The following is a description of a gene set: Reactome Pathway: PECAM1 interactions This event has been computationally inferred from an event that has been demonstrated in another species.<p>The inference is based on the homology mapping from PANTHER. Briefly, reactions for which all involved PhysicalEntities (in input, output and catalyst) have a mapped orthologue/paralogue (for complexes at least 75% of components must have a mapping) are inferred to the other species. species: Mus musculus part of: Cell surface interactions at the vascular wall electronically inferred by orthology from the curated human pathway, and this is the list of marker genes: Yes1, Fyn, Lck, Ptpn6